The following is a description of a gene set: Mouse Gene Set: GOBP_TRANSEPITHELIAL_TRANSPORT studied in species Mus musculus The directed movement of a substance from one side of an epithelium to the other., and this is the list of marker genes: Slc12a2, Slc26a6, Abcg3, Abcc2, Cldn19, Ahcyl1, Rhcg, Abcc1, Aqp8, Aqp1, Ostm1, Prss8, Ednrb, Itpr1, Abcb1a, Cftr, Abcg2, Best1, P2ry6, Clcn7, Cxadr, P2ry4, Rhbg, Scnn1b, Edn1, Clcnkb, Abcb1b, Gpld1, Cldn18, Cldn16, Clcnka, Cldn3, Actg1, Slc9a4, Actb, Csf2, Pkp1, Slc5a1